The following is a description of a gene set: The infant leukemia-associated gene Ott1 (Rbm15) has broad regulatory effects within murine hematopoiesis. However, germ line Ott1 deletion results in fetal demise prior to embryonic day 10.5, indicating additional developmental requirements for Ott1. The spen gene family, to which Ott1 belongs, has a transcriptional activation/repression domain and RNA recognition motifs and has a significant role in the development of the head and thorax in Drosophila melanogaster. Early Ott1-deficient embryos show growth retardation and incomplete closure of the notochord. Further analysis demonstrated placental defects in the spongiotrophoblast and syncytiotrophoblast layers, resulting in an arrest of vascular branching morphogenesis. The rescue of the placental defect using a conditional allele with a trophoblast-sparing cre transgene allowed embryos to form a normal placenta and survive gestation. This outcome showed that the process of vascular branching morphogenesis in Ott1-deficient animals was regulated by the trophoblast compartment rather than the fetal vasculature. Mice surviving to term manifested hyposplenia and abnormal cardiac development. Analysis of global gene expression of Ott1-deficient embryonic hearts showed an enrichment of hypoxia-related genes and a significant alteration of several candidate genes critical for cardiac development. Thus, Ott1-dependent pathways, in addition to being implicated in leukemogenesis, may also be important for the pathogenesis of placental insufficiency and cardiac malformations. Human Gene Set: RAFFEL_VEGFA_TARGETS_DN species: Mus musculus Genes down-regulated in hearts of E18.5 embryos upon knockout of VEGFA. from publication Raffel GD, Chu GC, Jesneck JL, Cullen DE, Bronson RT, Bernard OA, Gilliland DG (PMID 18981216), and this is the list of marker genes: IL18R1, HEY1, TLX1, NKX2-5, HES1 (NCBI Gene Id 3280)